The following is a description of a gene set: The component of the presynaptic membrane consisting of gene products and protein complexes that are loosely bound to one of its surfaces, but not integrated into the hydrophobic region. species: Mus musculus Mouse Gene Set: GOCC_EXTRINSIC_COMPONENT_OF_PRESYNAPTIC_MEMBRANE, and this is the list of marker genes: Snap91 (synaptosomal-associated protein 91), Phb1 (prohibitin 1), Ctnna2, Ap2s1, Snap25, Ap2b1, Ctbp1, C1qa, Stxbp1, Picalm, Rims1, C1qb, Cyth1, Stxbp5, Dnajc6, Ap2m1, Dgki, C1qc